The following is a description of a gene set: from publication Motenko H, Neuhauser SB, O'Keefe M, Richardson JE (PMID 26092688) studied in species Mus musculus Mouse genes annotated to increased lymphoma incidence (MP:0012431) retrieved from the Mouse Genome Informatics database via MouseMine Mouse Gene Set: MP_INCREASED_LYMPHOMA_INCIDENCE, and this is the list of marker genes: Cul9, Prdx1, Myc, Gpx7, Prdm2, Bub1b, Eaf2, Trp53bp2, Bub1, Nf2, Fhit, Dna2, Trp73, Rpa1, Stag1, Trim37, Mlh1, Per2, Smg1, Msh2, Dclre1a, Akt2, Nsmce2, Chfr, Pole, Pten, Ikzf1, Klf14 (NCBI Gene Id 676363), Uimc1, Mir21a, Nbn (nibrin), Usp44, Rassf1, Brca2, Trim62, S100a4, Mcm4 (NCBI Gene Id 17217), Chd2, Slc33a1, Hic1, Runx1, Plk1, Mdm2, Pinx1, Rad50, Atm, Hephl1, Mcm3, Msh6, Lzts1, Hmga1, Flcn, Kras, Bin3, Myh14, Nf1, Bcl11b, Rint1, Fasl, Apex1, Robo1, Blm, E2f1, Sod2, Pole4, Bap1, Rraga (NCBI Gene Id 68441), Cdc37, Cdkn2a (NCBI Gene Id 18560), Recql4, Becn1 (NCBI Gene Id 56208), Ssbp2, Ncoa3 (nuclear receptor coactivator 3), Rbbp8, Rb1 (NCBI Gene Id 19645), Sptbn1, Pml, Tgfbi, Smarcb1, Bad, Brip1, Sav1, Pim1, Maf, Tnk1, Mir125b-1, Lig1, Trp53, Srpx, Rbm38, Nrbp1, Irf8, Tusc2, Prf1, Ptch1, Abraxas1, Pold1, Fdxr, Ifng, Terc, Atad5, Cdc20, Exo1, Smurf2, Trp53bp1 (NCBI Gene Id 27223), Fbxo4, Anxa7, Ppp5c, Aurka, Rnf8, Ski, Tpx2, Fbxw7, Brca1, Rcbtb2, Pms2, Irf1, Nme1, Mus81, Met